The following is a description of a gene set: species: Homo sapiens Human Gene Set: GOCC_SMOOTH_ENDOPLASMIC_RETICULUM_MEMBRANE The lipid bilayer surrounding the smooth endoplasmic reticulum., and this is the list of marker genes: STX17, PGRMC1, SLCO1B3-SLCO1B7, FTCD, HSD3B1, HSD3B2, TTYH1, AQP8, SVIP, NAPEPLD